The following is a description of a gene set: studied in species Homo sapiens Binding to a C3HC4-type zinc finger domain of a protein. The C3HC4-type zinc finger is a variant of RING finger, is a cysteine-rich domain of 40 to 60 residues that coordinates two zinc ions, and has the consensus sequence: C-X2-C-X(9-39)-C-X(1-3)-H-X(2-3)-C-X2-C-X(4-48)-C-X2-C, where X is any amino acid. Many proteins containing a C3HC4-type RING finger play a key role in the ubiquitination pathway. Human Gene Set: GOMF_C3HC4_TYPE_RING_FINGER_DOMAIN_BINDING, and this is the list of marker genes: PINK1, HSPA1A, HSPA1B, DNAJA1, HSPA8